Given this list of marker genes EDNRB, ADRA2B, HTR7, DOCK4, DBH, TBXAS1, KCNMB2, TBXA2R, MANF, AVPR1A, ACE, SVEP1, HTR1D, COMP, ACTA2, MIR21, MAP2K1, AGT, EDN3, RHOA, PER2, MKKS, AVPR2, HTR1B, MMP2, TACR1, ADD3, ITGA9, HTR2B, CAV1, ITGB1, ECE1, SLC6A4, MTNR1B, ASIC2, P2RX1, BMPR2, FAAH (fatty acid amide hydrolase), AVP, EDN2 (endothelin 2), SLC8A1, CD38, ADRA1B, AGTR1, RAP1GDS1, BDKRB2, FGG, ADRA1A, ZDHHC21, KEL, ADRA2C, PIK3C2A, GRIP2, ATP1A2, HTR2A, TRPM4, SCNN1B, ATP2B1, APLN, BBS2, CRP, SMTNL1, ITGA4, ARHGAP42, ADM, F2R, KCNA5 (potassium voltage-gated channel subfamily A member 5), ADRA1D, STUB1, FGA, ABL1, AVPR1B, CASR (calcium sensing receptor), KCNMB4, HRH2, OXTR, LEP, DOCK5, DRD5, EDNRA, GJA5, ACE2, EDN1, FGB, HRH1, ADRA2A, HTR1A, here is a description of the gene set: Human Gene Set: GOBP_VASOCONSTRICTION A decrease in the diameter of blood vessels, especially arteries, due to constriction of smooth muscle cells that line the vessels, and usually causing an increase in blood pressure. species: Homo sapiens